Given this list of marker genes EIF2AK1, PSMC5, DDX39A, ZNF706, HMGN1, CCR7, ACAT1, NUP210, SSR4, CCDC59, PHB2, PDIA3, TTC3, TTC19, ERGIC3, SRSF3, CCND2, NDUFAB1, SLC25A38, GLRX5, BCKDHA, SUCLG2, MAPRE2, ATP5PD, HSP90B1, PLAC8, TSPYL4, PSMG2, EIF3M, CCT2, DDX1, NOL7, IMP4, PWP1, LRPPRC, HELZ, ATP5F1D (NCBI Gene Id 513), LGALS8, UTP3, PRKCH, SRSF2, GRPEL1, PRMT1, RNF113A, NAGPA, DYRK2, NELFCD, JADE2, LRRC8D, EPRS1, CDR2, FAM117A, RSL1D1, SUMO3, SGSH, C9orf78, SLC38A1, IPO5, ADH5, RPL26, NCL, PDHA1, SPOCK2, CD81, SUN2, MCM3, DAZAP1, ATXN10, BUD23, ERCC3, BUB3, TMEM243, ACVR1, ARFGAP2, HDAC1, TRA2B, ERCC5, RPL11, PTPN11, DUSP12, NMT1, EIF2B1, SIDT1, STRAP, EVL, NDUFV2, EIF3D, THAP11, POLR1D, AIMP1 (aminoacyl tRNA synthetase complex interacting multifunctional protein 1), GLO1, XPOT, FBXO21, AIFM1, ATRAID, ARHGEF3, PTCD3, MRPS35, ECHDC2, SARS1, DOCK10, RPL35A, SUPT7L, ATXN7L3B, TMEM147, SAE1, CCT8, GOLGA8B, SF3A3 (NCBI Gene Id 10946), PRP4K, HNRNPM, BRD7, EIF3L, NUP85 (nucleoporin 85), TBL1XR1, GLOD4 (glyoxalase domain containing 4), UPF3A, PEBP1 (phosphatidylethanolamine binding protein 1), NAP1L1, NDUFS3, NEK9, MALT1 (NCBI Gene Id 10892), PSMA1, COX11, YTHDC2 (YTH N6-methyladenosine RNA binding protein C2), SATB1, SNRPF, TCEA1, MMS19, IDH3B, PIK3R1, CMTR1, TUFM, RAN, COPS2 (NCBI Gene Id 9318), FBXO7, RPA1, TGIF1, VDAC2, ATP5PO, MIF, DGKA, UFC1, MRPL49, TRAF3IP3, MOAP1, FYN, BANF1, SYNE3, ZNF207, UXT, RBBP7, RPS25, DDX46, CCT4, SRSF7, GRSF1, SMARCE1, ESD, SAMHD1, CD52, FBXW2, RIOX1, KARS1, MDFIC, SRSF6, SNRPA, RTRAF (NCBI Gene Id 51637), DUT, DNAJC9, PSMB7, IARS2, SLC25A5, ECHS1, ATP5F1A, GMPS, RCN2, TES, ARL4C, YBX1, RNF220, SEC63, LARS1, CD7, ATP5MC3, RNH1, ERG28, PRKACB, AKR1B1, PRPS1, MFHAS1, ASXL1, GPI, GTPBP4, PAIP1, HMGN3, MTREX, SFPQ, GTF3A, here is a description of the gene set: Genes up-regulated in comparison of naive CD4 CD8 T cells versus unstimulated neutrophils. Immune cell-specific expression is one indication of the importance of a gene's role in the immune response. In order to identify such patterns, we set out to broadly profile gene expression in a variety of immune cells. from publication Abbas AR, Baldwin D, Ma Y, Ouyang W, Gurney A, Martin F, Fong S, van Lookeren Campagne M, Godowski P, Williams PM, Chan AC, Clark HF (PMID 15789058) Human Gene Set: GSE22886_NAIVE_TCELL_VS_NEUTROPHIL_UP studied in species Homo sapiens